The following is a description of a gene set: Genes predicted to be targets of miRBase v22 microRNA mmu_miR_3094_5p in miRDB v6.0 with MirTarget v4 prediction scores > 80 (high confidence targets). Mouse Gene Set: MIR_3094_5P species: Mus musculus from publication Chen Y, Wang X (PMID 31504780), and this is the list of marker genes: Bak1, Fam178b, Smarcb1, Il10rb, C1qtnf9 (C1q and tumor necrosis factor related protein 9), Tnp1, Sertad2, Speer1m, Rab19, Arhgap9, Tnfrsf11b (tumor necrosis factor receptor superfamily, member 11b (osteoprotegerin)), Tubgcp4, Slc7a4 (solute carrier family 7 (cationic amino acid transporter, y+ system), member 4), Prr3, Krtap9-22, Stc1, Fam78b, Slc39a13, Elfn2 (leucine rich repeat and fibronectin type III, extracellular 2), Agap2, Ubtf, Camk1d, Prkcg, Speer1e (spermatogenesis associated glutamate (E)-rich protein 1E), Dnajc14, Mmd2, Rep15, Upk1a, Speer1a, Speer1h, Klrb1c, 6030458C11Rik, Stoml1, Itgae, Trip6, Elavl1, Mfsd11, Hnrnpd, Mecp2, Plpbp, Opcml, Zfp579, Clock, Akap5, Plekhh1 (pleckstrin homology domain containing, family H (with MyTH4 domain) member 1), Cyp26b1, Vmn2r81, Prr23a3, Ddx42, Kcnip1, Git1, Met, Lrrc4b, Stxbp5l, Pgrmc2, Tmem121b, Pard3, Lrrn4, Etnppl, Ppp1r13l, Strn4, Cluap1, Irag2, Adm2, Gipc1, Col1a2, B3gnt3, Tns1